Given this list of marker genes CALM3, CASP4, GBP1, CALM1, SERPINB1, CALM2, GBP4, GBP2, GBP3, ospC3, here is a description of the gene set: part of: Non-canonical inflammasome activation Caspase-4 (CASP4) is an inflammatory caspase involved in the innate immune response, particularly against Gram-negative bacteria, and is activated when intracellular bacterial lipopolysaccharide (LPS) binds to the N-terminal caspase activation and recruitment domain (CARD) of CASP4 (Shi J et al., 2014; An J et al., 2019, 2022; Wang K et al., 2020). LPS can enter the host cell cytosol through several mechanisms, including endocytosis of LPS-containing outer membrane vesicles (OMVs), which are naturally secreted by Gram-negative bacteria (Wacker MA et al., 2017; Bitto NJ et al., 2018; reviewed by Barker JH & Weiss JP 2019; Page MJ et al., 2022). Additionally, LPS may be released from phagocytosed bacteria following the rupture of phagolysosomal compartments, allowing bacterial components to escape into the host cytosol. Guanylate-binding proteins (GBPs), a family of interferon-inducible, dynamin-like GTPases, localize to pathogen-containing vacuoles or directly to exposed LPS on the bacterial cell surface. There, GBPs, namely, GBP1, GBP2, GBP3 and GBP4, assemble into a supramolecular complex known as the GBP coat, which disrupt bacterial membranes and exposes LPS to the cytosol, thereby promoting CASP4 recruitment (Santos JC et al., 2020, Wandel MP et al., 2020). LPS-bound CASP4 oligomerizes and undergoes self-cleavage at specific sites, leading to the full proteolytic activity (Wang K et al., 2020; Chan AH et al., 2023).<p>Activated CASP4 can then cleave gasdermin D (GSDMD), which is also a substrate of CASP1, CASP5, and Casp11, a murine homolog of human CASP4/CASP5 (Shi J et al., 2014, 2015; Kayagaki N et al., 2015; Zhao Y et al., 2018; Wang K et al., 2020). The resulting N-terminal fragment of GSDMD oligomerizes to form pores in the cell membrane, leading to pyroptosis in mammals (Liu X et al., 2016; Ding J et al., 2016; Sborgi L et al., 2016; Aglietti RA et al., 2016). In addition, CASP4 and CASP5 cleave pro-interleukin-18 (pro-IL-18) at aspartic acid D36 with high efficiency, producing the mature, active cytokine (Shi X et al., 2023; Exconde PM et al., 2023; Devant P et al., 2023; reviewed by Exconde PM, 2024). Structural analyses revealed that this cleavage relies on a bivalent recognition mechanism, in which pro-IL-18 binds caspase-4 through two interfaces: the protease exosite binds a hydrophobic pocket within pro-IL-18, while the active site of CASP4 engages charged residues located within and adjacent to the tetrapeptide recognition motif in the pro-domain (Shi X et al., 2023; Devant P et al., 2023). In contrast, CASP4- and CASP5-mediated cleavage of pro-IL-1β at D27 produces an inactive fragment that lacks receptor-stimulating activity (Exconde PM et al., 2023; reviewed by Exconde PM, 2024). An alternative CASP4-mediated cleavage at D116, the canonical pro-IL-1β activation site, has been observed but occurs with lower efficiency comparing to pro-IL-18 processing (Bibo-Verdugo B et al., 2020; Chan AH et al., 2023; Devant P et al., 2023).<p>Intracellular bacterial pathogens have evolved strategies to suppress host inflammatory responses. For example, Shigella flexneri secretes the type III secretion system (T3SS) effector OspC3, which catalyzes ADP-riboxanation of CASP4, thereby inhibiting LPS-induced, CASP4-mediated pyroptosis (Li Z et al., 2021; Hou Y et al., 2023).<br> Reactome Pathway: CASP4 inflammasome assembly species: Homo sapiens